The following is a description of a gene set: Any process that activates or increases the frequency, rate or extent of a defense response. Mouse Gene Set: GOBP_POSITIVE_REGULATION_OF_DEFENSE_RESPONSE studied in species Mus musculus, and this is the list of marker genes: Card9, Ncr3-ps, Klri2, Irf7, Tradd, Trim30a, Gpr108, Rela, Prkce, Lgals9, Brcc3dc, C1qbp, Klrb1c (killer cell lectin-like receptor subfamily B member 1C), Kars1, Ddx3x, Polr3b, P2rx7, Nlrc4, Tspan6, Nlrc3, Nectin2, Polr3f, Erbin, Cpt1a, Klrc2, Adam8, Vamp8, Ticam1, Cd36, Park7 (Parkinson disease (autosomal recessive, early onset) 7), Tmem126a, Dhx58, Grpr, S100a8, Mdk, Acod1, Epg5, Gdi1, Atat1, Nlrp1a, Irf3, Cd300a, Tyro3, Zdhhc5, Il17ra, Znrf4, Il1b, Bpifb1, Rsad2, Prkd1, Zdhhc9, Tlr8, Klk7, Rasgrp4, Dhx9, Ido1, Tasl, Ly96, Npy5r, Gbp3, Ldlr, Tkfc, Usp29, Ereg, Pqbp1, Tlr1, Oasl1, Trex1, Emilin2, S100a9, Lgr4, Mmp8, Gbp2b, Esr1, Cadm1, Mef2c, Rab7b, Sin3a, Tnfsf11, Btk, Fpr2, Cebpa, Cd226, Ifi203-ps, Ccl1, Klrc3, Fpr-rs7, Gps2, Traf6, Sec14l1, Rab34, Gbp2, Lrrc14, Trim31, Hsp90aa1, Nod1 (nucleotide-binding oligomerization domain containing 1), Tlr5, Fbxl2, Mndal, Ticam2, Tyrobp, Gpatch3, Fcna, Zdhhc3, Ptprs (NCBI Gene Id 19280), Xiap, Cd160, Ptger3, Ppp2ca, Tlr2, Sucnr1, Med1, Casp12, Fadd, Trim56 (NCBI Gene Id 384309), Klrk1, Fabp4, Tomm70a, Ankrd17, Gja1, Il18rap, Gm15441, Lats2, Unc13b, Oas1d, Il1rl1, Ubqln1, Dhx33, Ppt1, Il12b, Sfpq, Xrcc5, Ifi213, Cxcl1, Tslp, Plcg2, Arg1, Xcl1, Klrc1, Tril, Casp4, S100a14, Fcer1g, Ifih1, Ifi209, Tirap, Traf3ip3, Polr3g, Bcl10, Optn, Spi1 (Spi-1 proto-oncogene), Syk, Ifi35, Cd300lf, Npas2 (NCBI Gene Id 18143), Ulbp1, Trem3, Gramd4, Dab2ip, Sh2d1a, Znrf1, Pla2g5, Il6, Oas1b, Slc46a2, Irf1, Tnfrsf11a, Casp6, Oas1c, Usp15, Arf6, Rab11fip2, Aars2, Lrrc19, Oas1h, Gpsm3, Rnf144a, Cyba, Tlr12, Tnfsf4, Otud4 (NCBI Gene Id 73945), Hspa8, Adora2b, Ecsit, Cav1, Klk5, Mark4, Peli3, Penk, Ucn, Oas1a, Gm12250, Trem2, F2rl1, Clnk, Ptger4, Serpine1, Mefv, Klre1, Srebf1, Vav1, Tlr7, Polr3d, Brcc3, Camk2n1, Fem1a, Il17a, Casp3 (NCBI Gene Id 12367), Lyplal1, Slc19a1, Ufd1, Trim12c, Cptp, Ppp6c, Klri1, Lrrk2, Nfkbia (nuclear factor of kappa light polypeptide gene enhancer in B cells inhibitor, alpha), Mmrn2, Mavs, Rnf31 (NCBI Gene Id 85306), Raet1e, Zbp1, Oas3, Nploc4, Rtn4, Ifi206, Lbp, Traf3, Emilin1 (elastin microfibril interfacer 1), Irgm1, Kcnj8 (NCBI Gene Id 16523), Tlr13, Tbk1, Colec12, Lyn, Lrch4, Kcnk13, Aim2, Rps19, Sh2d1b2, Gbp5, Pik3ap1, Ap1g1, Appl1, Usp17le, Tnfaip3, Fcnb, Myd88, Xrcc6, Trim30d, Scimp, Aurkb, Zdhhc1, Ifi204, Unc93b1, Nlrx1, Il12a, Rbm47, Stmp1 (NCBI Gene Id 67705), Raet1d, Ddt, Tnip3, Trim41, Tnfsf18, Pdcd4, Smpdl3a, Nlrp10, D1Pas1, Fcgr1, Cactin, H2-T23, Pde2a, Mapk8, Abhd17a, Tac1, Tgfb1, Tnip1 (NCBI Gene Id 57783), Cd24a, Ighg2b (NCBI Gene Id 16016), Ogt, Alox5ap, Nupr1, Gfi1, C3, Phb2, Fpr-rs6, Oas1g, Trpv4, Becn1, Slc15a2, Wnt5a, Ccl24, Tifa, Gimap3, Sqstm1, Clock, Eif2ak2, Sting1, Map3k7, Pum2, Ninj1, Cx3cl1, Rnf170, Lamp2 (lysosomal-associated membrane protein 2), Irak1, Cd28, Mfhas1, Ccr2, Tafa3, Ccdc134, Gpr4, Nfkbil1, Lacc1, Lpl, Rps6ka3, Polr3c, Gbp7, Pgc, Lilra5, Ripk2, Trim62, Slc15a3, Il17rb, Prkdc, Aoc3, Znfx1, Elp6, Otulin, Usp27x, Ffar3, Cd74, Treml4, Pspc1, Src, Gimap5, Cd47, Lamp1, Zp3, Ltf, Clec4n, Ifi214, Crh, Hmgb1, Tlr4, Zdhhc4, Letmd1, Kcnn4, Nono, Ipo5, Cgas, Trim11, Pvr, Cd86, Tlr3, Dpp4, Akt1, Trim32, Pdpk1 (NCBI Gene Id 18607), Ccl3, Abcc1, Peli1, Hmgb2, Il21, Naglu, Mapkapk3, Tifab, Lrrfip2, Trim30c, Lgals2 (lectin, galactose-binding, soluble 2), Irf2, Wdfy1, App, Oas1e, Nkg7, Rnf185, Klrd1, Rigi, Zdhhc12, Gkn2, Itch, Parp9, Snx4, Tab1, Grn, Rnf125, Nlrp3, Hexim1, Trim25, Nlrp6, Tnfrsf1a, Il18, Pycard, Rftn1, Pomc (pro-opiomelanocortin-alpha), Gsdmd, Cd300ld3, Ifi211, Trim3, Ccl5, Csnk1a1, Trim6, Fcgr3, Tax1bp1 (Tax1 (human T cell leukemia virus type I) binding protein 1), Mbl2 (mannose-binding lectin (protein C) 2), Snca, Arrb2, Ptgs2, Chuk, Ighg1, Lats1, Zdhhc18, Adora3, Nlrc5, Txk, Tnip2, Ifi203 (interferon activated gene 203), Fpr-rs4, Havcr2, Htr2a, Sirt2, Ap3b1, Washc4, Pik3cg, Hyal2, Nr1d1, Trim12a, Phb1, Lrsam1, Pik3r1, Ptgs2os, Hpx, C2cd4a, Akirin2, Irak3, Cebpb, Zcchc3, Pde5a, Casp1, Slc15a4, Nppa, Tnf, Clec4e, Pla2g3, Tlr9, Gprc5b, Tarbp2, Napepld, Stat5b, Clpb (ClpB caseinolytic peptidase B), Rbm14, Ikbke, Il17f, Usp50, Trim5, Trim30b, Hcfc2, Lag3, Appl2, Lsm14a, Nfkbiz, Smpdl3b, Stat5a, Ccr5, Setd4, Ywhae, Ffar2, Map3k8, Csf1r, Igtp, Irgm2, Ddx60, C2cd4b, Rnf135, Riok3, Matr3, Plscr1, Mapk3, Rasgrp1, Ifi207, Slamf6, Reg3g, Cd14, Lgals1, Kat5, Parp1, Flot1, Ifng, Stap1, Nagk (NCBI Gene Id 56174), Ctsc, Alpk1, Ttbk1, Ctss, Tlr6, Nlrp1b, Ccr7, Ube2k, Sh2d1b1, Zc3hav1, Pcbp2, Rnf34, Cck, Cckbr, Fosl1, Oas1f, Inava, Crtam, Rnf115, Hspd1, Cnr1, Nek7, Nr1h3, Cd274, Osm, Trim15, Hspa1b, Nod2, Clec7a, Pum1, Mapkapk2, Ptpn22, Cd81, Ets1, Sarm1, Mmp12, Tlr11, Nr1h4, Prkca, Irf4, Banf1, Ripk1, Nmi, Pja2, Fpr-rs3, Spsb3, Ifi208, Fcer1a, Il33, Ccn4, Lta, Grp, Irak2, Nop53, Il16, Ifi205, H2-M3